The following is a description of a gene set: Genes up-regulated in thymic implants from fetal versus those from adult bone marrow. Human fetal and adult hematopoietic stem cells (HSC) were obtained from fetal liver, fetal bone marrow (BM), and adult BM. These were injected into human fetal thymic implants in SCID-hu Thy/Liv mice (4-6 separate mice per HSC donor) and allowed to mature into single positive CD4+ (SP4) thymocytes over the course of 7-8 weeks. SP4 thymocytes from injected stem cells were subsequently sort-purified from thymic implants and gene expression was performed. studied in species Homo sapiens from publication Mold JE, Venkatasubrahmanyam S, Burt TD, Michaëlsson J, Rivera JM, Galkina SA, Weinberg K, Stoddart CA, McCune JM (PMID 21164017) Human Gene Set: GSE25085_FETAL_BM_VS_ADULT_BM_SP4_THYMIC_IMPLANT_UP, and this is the list of marker genes: AIMP2, UNC93B1, HMOX2, BZW2, LTO1, IFNAR1, GASK1B, RNF19B, TDRD7, CD40, JPH2, AHSA1 (NCBI Gene Id 10598), UNC50, TUSC1, TAPBP, LMBR1, NT5C3A, SAV1, ATP6V0C, RAB20, RTP4, CGAS, FNBP1L, PPM1G, GJC1, CNP, HAO2, AIDA (axin interactor, dorsalization associated, NCBI Gene Id 92615), HELZ2, LY9, GLRX, NADK, LACC1, DEGS1, DNAJA3, DIO2, SEMA4D, MAFG, BATF2, PPA1, CERS6, LRP12, IFIH1, HSD17B12, PTTG1, RBPJ, LIPA, MVP, TPM3, HCAR2, TMCC3, SLC35B1, HLA-B, P3H3, KAT2A, ADAM19, SLC31A2, ISG20, NRROS, DDX18, NR2F2, SERPINB9, ACER3, FABP5, OASL, IFIT1B, NAB1, SRGAP2, SAMD9L, MAT2A, ENPP4, IRF7, ZFAND5, IL7R, MMP13, PNPT1, RSAD2, SELENOS, WSB2, IFIT2, GSDME, SLC39A10, TPST2, CDKN1C, DDIT3, ISG15, TSR1, EGR1, PCGF5 (polycomb group ring finger 5), TRAF3, SYNJ1, ST6GALNAC4, IGF2BP2, PDXK, PLXNA2, TAPBPL, RMDN3, CALHM6, STAP1, MYD88 (MYD88 innate immune signal transduction adaptor), TRIM44, HERC6, EIF1AY, ZBP1, SLFN13, ENTPD6, NGRN, RELB, TMEM230, MTHFD2, TRMT61A, HPSE, SMYD5, IFI35, AKAP10, CMPK2, TRAF1, SORL1, PDE7B (NCBI Gene Id 27115), CAMTA2, ZCCHC2, H1-2, CHMP4B, SOCS3, TRIM14, CD86, SERF2, MARCHF5, ADCY3, MAGOHB, LY6E (NCBI Gene Id 7999), TGFBR2, SPPL2A, JAK2, COX18, GALNT11 (polypeptide N-acetylgalactosaminyltransferase 11), PPP1R15A, DDX60, TRIM34, SPIC, DIAPH2, GBP4, PLEKHO2, OGFR, FLRT2, PSMB8 (proteasome 20S subunit beta 8), NOP56, CWC22, SRSF3, MMP9, TBC1D8, CLCN7, BRIX1, ZC3H12C, LENG1, GNAS, CCT3, OAS2, ZUP1, SP110, CCL4, CXCL11, C11orf68, CD82, ANXA1, LCP2 (NCBI Gene Id 3937), PARP14, IDE, ELL2, SERTAD1, APP, MTDH, CD180, PAWR, ADGRL2, DDX39B, IFIT3, GLG1, CDYL2, TRIM21, TASOR, VEGFA, ZBTB2, MX2 (NCBI Gene Id 4600), MRPL12, PCCA, SDC4, DPH6, PARP12, COL6A2, MRPS2 (mitochondrial ribosomal protein S2), NFE2L2, PPFIBP2, METRNL, PSME1, UBC, FOXRED1, CDK14, PDE4B, ATF3